The following is a description of a gene set: Mouse Gene Set: GOBP_MODIFICATION_OF_SYNAPTIC_STRUCTURE species: Mus musculus Any process that modifies the structure/morphology of a synapse., and this is the list of marker genes: Zdhhc17, Cap1 (cyclase associated actin cytoskeleton regulatory protein 1), Itpka (inositol 1,4,5-trisphosphate 3-kinase A), Pfn2, Gripap1, Kalrn, Ctnna2, Wasf3, Chmp2b, Dlgap3, Egln1, Camkv, Pgrmc1, Epha4, Nf1, Rap1b, Abi3, Gsk3b, Rhob, Myo5b, Marcks (NCBI Gene Id 17118), Sptb (spectrin beta, erythrocytic), Ptk2, Cdc42, Cln3, Prmt8, Amot, Pdxp, Abl1, Cap2, Synpo (NCBI Gene Id 77694), Rest, Stau1, Myh10, Rapgef2, Tiam1, Pfn1, Wasf1, Dip2a, Rhoa, Drd1, Cabp1, Sarm1, Dlgap4, Arhgap44, Itsn1 (intersectin 1 (SH3 domain protein 1A)), Dixdc1, Cttn, Cfl1, Cttnbp2, Strn4 (striatin, calmodulin binding protein 4), Baiap2, Cyfip1, Filip1, Kif5b